The following is a description of a gene set: part of: N-glycan antennae elongation in the medial/trans-Golgi N-glycans are further modified after the commitment to Complex or Hybrid N-glycans. The exact structure of the network of metabolic reactions involved is complex and not yet validated experimentally. Here we will show a generic reaction for each of the genes known to be involved in N-Glycosylation.<br>For a better annotation of the reactions and genes involved in the synthesis of Complex and Hybrid N-glycans we recommend the GlycoGene Database (Ito H. et al, 2010) (http://riodb.ibase.aist.go.jp/rcmg/ggdb/textsearch.jsp) for annotations of genes, and the Consortium for Functional Genomics (http://riodb.ibase.aist.go.jp/rcmg/ggdb/textsearch.jsp) for annotation of Glycan structures and reactions. Moreover, a computationally inferred prediction for the structure of this network is available through the software GlycoVis (Hossler P. et. al. 2006). Reactome Pathway: N-Glycan antennae elongation studied in species Homo sapiens, and this is the list of marker genes: B4GALT5 (NCBI Gene Id 9334), B4GALT6, ST6GAL1, ST3GAL4, ST8SIA3, B4GALT1, MGAT4C, B4GALT4 (NCBI Gene Id 8702), MGAT4B, MGAT5, ST8SIA6, MGAT4A, ST8SIA2, B4GALT2, B4GALT3 (beta-1,4-galactosyltransferase 3)